The following is a description of a gene set: Genes up-regulated in comparison of dendritic cells (DC) stimulated with LPS (TLR4 agonist) at 0.5 h versus those stimulated at 8 h. from publication Amit I, Garber M, Chevrier N, Leite AP, Donner Y, Eisenhaure T, Guttman M, Grenier JK, Li W, Zuk O, Schubert LA, Birditt B, Shay T, Goren A, Zhang X, Smith Z, Deering R, McDonald RC, Cabili M, Bernstein BE, Rinn JL, Meissner A, Root DE, Hacohen N, Regev A (PMID 19729616) mouse primary BMDCs were stimulated with tlr ligands and gene expression changes were profiled on Affymetrix arrays species: Homo sapiens Human Gene Set: GSE17721_0.5H_VS_8H_LPS_BMDC_UP, and this is the list of marker genes: NAXE, RBX1, ZNF318, HABP4, GALK2, KCNN4, DAP, MAU2, GCLM, NQO2, YBX3, AVPI1, LSM4 (NCBI Gene Id 25804), PARK7, SH3BGRL3, C1orf174, XPR1 (NCBI Gene Id 9213), ATRX, MAPK3, ZBTB25, CILK1, SOCS6, MANBA, ATRAID, TUBA1A, TGFBI, PIK3CG, PIP4K2A, ENTPD1, DUSP19, MRPL30, GALNT2, THYN1, ELP2, SEC24D, FAM50A, CCNB2, SLC4A1AP, IPO8, DCXR, ERMP1, SRF, IER2, MCM7, TFB2M, LDLRAP1, ZMPSTE24, C8G, ZDHHC4, ALDOAP2, CORO1A, CHCHD7, TMEM141, COMMD6, RPL12, RPS3, DGCR6, C19orf53, SLC7A7, PGF, NSMF, PPIH, POLR2D, HEBP2, SVIL, GPT, TXNL4A, PDE6B, HIGD2A, PNKD, MRC1, MEA1, HDAC5, SLC25A4, ADCY4, ZNF518B, DDX56, ACTL6A, URM1, PHKG2 (NCBI Gene Id 5261), ADRB2, DUSP6, PRMT3, DCPS, METTL1, CUEDC2 (NCBI Gene Id 79004), GNPDA1, HHEX, PGRMC2, ASCC1, MAD1L1, CTR9, PPIB, NIFK, RWDD4, FAM53A, PHF5A, PLEKHG2, IMPA2, ERCC5, MKNK2, CENPV, PEPD, ARMC6, ELOVL6 (NCBI Gene Id 79071), TUBB2B, AKR7A2, CEACAM21, PARVG, MCOLN1, MRPL42, HTATIP2, TPD52L2, TDP1, KXD1, RANBP3, ESRRA, CDC6, SORBS3, TRIM3, CDK1, PROM1, PUS7, PALD1, TSPAN14, NUP93, ATG3, ACADS, RAP1GAP, MIDN, PRSS16, FAF1, N4BP3, NEU1, SLC46A2, P2RX3, MRPL55, MRPL28, NR4A1, COA7, FGF3, ACO2, CLTB, IDH3A, PALS2, CMIP, DHCR24, ACOT13, ABCG8, PIGB (NCBI Gene Id 9488), GADD45GIP1, RPL13A (ribosomal protein L13a), RGS19, ZMIZ2, KCNJ11, SRR, YPEL1, MRPS15, CETN2, RPL38 (ribosomal protein L38), CPT1A, PPP1CC, IFI30, CD48, KLRD1, NCBP1, OSBPL2, CDH13, MRPL39, ADRA1A, ACAT1, RGL2, UGGT1, HIP1, ZBTB14, PACS1, CISD1, NUP35 (NCBI Gene Id 129401), ANLN, CDK4, SIK1, MAP6, ZNF703, DAPK1, RTCB, TTC4, FAM162A, CEL, XPC, ARHGAP39, CYP51A1, RGS10, MRPL34, SEPTIN8, DIP2B, ARL4D, PAG1, RPL6, ATP6V0A2